The following is a description of a gene set: from publication Bystrykh L, Weersing E, Dontje B, Sutton S, Pletcher MT, Wiltshire T, Su AI, Vellenga E, Wang J, Manly KF, Lu L, Chesler EJ, Alberts R, Jansen RC, Williams RW, Cooke MP, de Haan G (PMID 15711547) studied in species Mus musculus We combined large-scale mRNA expression analysis and gene mapping to identify genes and loci that control hematopoietic stem cell (HSC) function. We measured mRNA expression levels in purified HSCs isolated from a panel of densely genotyped recombinant inbred mouse strains. We mapped quantitative trait loci (QTLs) associated with variation in expression of thousands of transcripts. By comparing the physical transcript position with the location of the controlling QTL, we identified polymorphic cis-acting stem cell genes. We also identified multiple trans-acting control loci that modify expression of large numbers of genes. These groups of coregulated transcripts identify pathways that specify variation in stem cells. We illustrate this concept with the identification of candidate genes involved with HSC turnover. We compared expression QTLs in HSCs and brain from the same mice and identified both shared and tissue-specific QTLs. Our data are accessible through WebQTL, a web-based interface that allows custom genetic linkage analysis and identification of coregulated transcripts. Mouse Gene Set: BYSTRYKH_HEMATOPOIESIS_STEM_CELL_AND_BRAIN_QTL_CIS Genes associated with the same cis-regulatory QTL (quantitative trait loci) in both brain and hematopoietic stem cells (HSC)., and this is the list of marker genes: Sc5d, 4833420G17Rik, Med1, Rpl26, Mrps7, Srp9, Dda1, Dpp7, Ifi205, Usp38, Glo1, Skp1, Gatad2a, Ocel1, Ccnd2, Prkce, Alad, Mrpl35, Arhgap9, Ctsc, Hjurp, Zfp617, Eef1akmt1, Spg21, Zfp91, Cpsf2, Ndufa7, Acadl, Gemin5, Cux1, Saraf, Zfand5, Kmt2e, 6330403K07Rik, Mtif2, Hars1, Thumpd1, Trmt1, Dap3, Gnb1, Myo7a, Padi2, Klc1, Nop10, Acaa1a, Clec16a, Snhg6, Kcnj9, Psmb6, Vps52, Dctn6, Mrpl44, Gfer, Eloa, Prdx2, Zmym6, Agtrap, Snrpb2, Tubgcp4, Scoc, Aldh9a1, Iqgap1, Necap2, Pdxdc1 (pyridoxal-dependent decarboxylase domain containing 1), Fam114a2, Ptprf, Arl6ip1, Snhg1, Tox4 (TOX high mobility group box family member 4)